The following is a description of a gene set: This event has been computationally inferred from an event that has been demonstrated in another species.<p>The inference is based on the homology mapping from PANTHER. Briefly, reactions for which all involved PhysicalEntities (in input, output and catalyst) have a mapped orthologue/paralogue (for complexes at least 75% of components must have a mapping) are inferred to the other species. Reactome Pathway: Platelet homeostasis electronically inferred by orthology from the curated human pathway part of: Hemostasis species: Mus musculus, and this is the list of marker genes: Ppp2r5a, Ptpn6, Gngt1, Fgr, Trpc6, Ptgir, Atp2b4, Ppp2r5b, P2rx2, Gng5, Lrp8, Gng11, Calm1, Gng4 (guanine nucleotide binding protein (G protein), gamma 4), Nos2, Gnb3, Ppp2r5d, Ppp2r1b, Gng8, Atp2a1, Pde5a, P2rx6, Atp2b1, Gngt2, Gng10, Pde9a, Pde10a, Pde1b, Atp2b3, P2rx5, Mapk14, Gnb5, Pde2a, Gng3, Apob, P2rx7, Gnb2, Atp2a3, Gng7, Trpc7